The following is a description of a gene set: Any process that modulates the frequency, rate or extent of lymphoid progenitor cell differentiation. Human Gene Set: GOBP_REGULATION_OF_LYMPHOID_PROGENITOR_CELL_DIFFERENTIATION species: Homo sapiens, and this is the list of marker genes: SOS2, SOS1, ZBTB1, ZNHIT1, NUDT21, ANKLE1, FLCN, FNIP1, PCID2, HES5, HES1, NOTCH1